Given this list of marker genes Bbs9, Bbs2, Bbs5, Ttc8, Bbs4, Bbs7, Bbs1, Bbip1, here is a description of the gene set: A ciliary protein complex involved in cilium biogenesis. It consists of at least seven Bardet-Biedl syndrome (BBS) proteins and BBIP10. It moves in association with IFT trains through cilia (likely as an IFT-A/B adaptor or cargo), and is required for the integrity of IFT-A and IFT-B. species: Mus musculus Mouse Gene Set: GOCC_BBSOME